Given this list of marker genes Haus7, Camsap1, Cep290, Numa1, Tubgcp3, Macf1, Tmod3, Tubgcp2, Tubgcp6, Tubgcp5, Tubgcp4, Haus4, Camsap3, Nin, Camsap2, here is a description of the gene set: Mouse Gene Set: GOMF_MICROTUBULE_MINUS_END_BINDING species: Mus musculus Binding to the minus end of a microtubule.